The following is a description of a gene set: Human Gene Set: MANNO_MIDBRAIN_NEUROTYPES_HNBML5 from publication La Manno G, Gyllborg D, Codeluppi S, Nishimura K, Salto C, Zeisel A, Borm LE, Stott SRW, Toledo EM, Villaescusa JC, Lönnerberg P, Ryge J, Barker RA, Arenas E, Linnarsson S (PMID 27716510) Cell types are named using anatomical and functional mnemonics prefixed by 'm' or'h' to indicate mouse and human respectively: OMTN, oculomotor and trochlear nucleus; Sert, serotonergic; NbM, medial neuroblast; NbDA, neuroblast dopaminergic; DA0-2, dopaminergic neurons; RN, red nucleus; Gaba1-2, GABAergic neurons; mNbL1-2, lateral neuroblasts; NbML1-5, mediolateral neuroblasts; NProg, neuronal progenitor; Prog, progenitor medial floorplate (FPM), lateral floorplate (FPL), midline (M), basal plate (BP); Rgl1-3, radial glia-like cells; Mgl, microglia; Endo, endothelial cells; Peric, pericytes; Epend, ependymal; OPC, oligodendrocyte precursor cells. studied in species Homo sapiens, and this is the list of marker genes: PGM2L1, NPTXR, HIVEP3, SPEG, CACNA1G, FBXL12, TAL1 (NCBI Gene Id 6886), THSD7A, CHN2, FGF14, TSIX, PLEKHA6, FICD, RAB11FIP4, DPYSL3, KIF21B (NCBI Gene Id 54770), OPCML, PLPPR1, FRY, CDH13, AFF2, CELF3 (CUGBP Elav-like family member 3), STXBP1, JAKMIP2, SLC38A1, FABP3, HOOK1 (hook microtubule tethering protein 1), GPR137C, NREP, PLPP2, SCN8A, CD24, NOVA1, DACT1, DOT1L, KDM5B, SBK1, MAPRE3, CLUL1, FNDC9, NCDN (NCBI Gene Id 23154), OPN5 (NCBI Gene Id 221391), CEP126, TNFRSF6B, SCAI, ZNF793, ZNF776, MEG3, PLXNA4, ZHX1, CRACD, TMEM132B, PPP1R17, SPEF1, KLF7, PRKAR2B, USP49, GRIP1, HBB, ZNF697, TCERG1L, PTPRO, GABRB2, SSBP3, GRIA4 (NCBI Gene Id 2893), ADD2, PHACTR3, PDS5B, NXPH2, DCC, BSN, PCDH7, ARPP21, GATA3, SLC37A1, SRRM3, KALRN, ST18, DGKE, FUT9, PITPNC1, RBFOX2, ZFHX3, MTUS2, PRKCB, MAP6, UBE2QL1, ATCAY, VSTM2B, ZNF195, PAK3, GRM7, CNTNAP2, PLXNA3, FOXA2, CACNG2, SMAD9, ENO2, NRXN1, USP27X, ANKRD13B, CTSC, SOX1, PHF21B, RIMS4, TAC1, LONRF2, CORO2A, PAQR5, L1CAM, PSD2, BICD1, DOK6, SEPTIN3, SAMD11, FAM117B, BASP1, SEC31B, LMTK3, SIX3, PRKACB, PHYHIPL, MYT1, AATK, NOL4, DNER, TMEM121B, EYA1, ACVR1B, RBFOX1, LARP1B, TMEM192, SLITRK4, TSPOAP1, STRIP1, AKAP1, KIRREL3, C22orf42, DMTN, BEND4, GRIA1, CCDC112, NKAIN2 (NCBI Gene Id 154215), CMIP, ROBO2, REEP2, ATP8A1, AUTS2, SRRM4, SLC16A9, NCAN, SNAP25, LINGO1, DUSP26, NELL1, BHLHE22, NCS1, UNC13A, ENC1, TUBB3, NAV1 (neuron navigator 1), SLC12A5, TRHDE-AS1, CDH4, ZNF117, YWHAG, DUSP4, PTPRT, OSBPL6, SOX14, SULT4A1, GPR26, KSR2, POU2F1, ANKS1B, PAX5, PPFIA2, STK32B, USH2A, LMO1, TAFA2, KIF5C, KCNH8, SMPD3 (NCBI Gene Id 79756), MSANTD3-TMEFF1, CELF5, CBLN4, RCOR2, MAP3K9 (NCBI Gene Id 4293), XPR1, NOVA2, NALF1, PLXNC1, RGS7BP, RALGPS1, APBA2, MVB12B, GAD2, ABLIM3, ZNF385D, CADPS, RYR2, SIX3-AS1, ROBO1, FGF9, APLP1, PDP1, PAPPA, IRX2, ELAVL4, INSM1, CHST1, ACVR2A, TMOD2, TAOK3, SPOCK3 (SPARC (osteonectin), cwcv and kazal like domains proteoglycan 3), NBEA, SYTL2, RIMS2, PEG3, FMN2, STMN4, SYNPR, SH3BP5, CCDC85B, TAGLN3, LRRTM2, SLC8A2, RIMS1, MLLT11, MMP24, GATA3-AS1, PAPPA2, MFSD6, EPB41, PDZD7, AJAP1, HS3ST4, ONECUT1, GABRA1, CXADR, LHX5-AS1, COMTD1, TMEM169, HS6ST3, ANK3, ASXL3, HDAC1, ADGRB3, MAP1B, FSD2, MAST1, NSG2, MAP2, TRIM13, EMX2, PROX1, LHFPL4, SOX11, APC2, ESRRG, NEDD4L, SNORA12, DICER1, ZNF283, TENM1, CELSR3, APOL6, HCN3, GSE1, ASIC1, KIF21A, MACROH2A2, NRXN3, TSHZ2, TERF2IP, TENM2, OPTN, ANKRD44, DLG3, IGBP1, SEZ6L2, NSG1, HERC1, TLCD3B, NAP1L3, SCRT2, MDGA1, ATOSA, LMOD3, TRIM67, NALCN, ANKIB1, SCN3A, BCL11A, ELAVL2, TOX2, KLC1, MCF2, DCX (NCBI Gene Id 1641), TUBB2B, F11R, GNG3, SHISA2, MDGA2, KLHL14, RIPOR2, JPH4, NTNG1, ERC2, MARK1, PNOC, SRCIN1, SHANK2, MACO1, KLHL35, CLCN4, DNAJC16, RNF112, TCERG1, SCD5, MIAT, SYBU, GPR12, TMCC1, AASDHPPT, SCN3B, PIANP, FRMD5, DNAJC6, CPEB4, PLXNA2, GPM6A, EMX2OS, IRGQ, GNPTAB, CDK5R1, NFASC, ZC3H12C, PCDH11X, NRXN2, ATP1A3, ZBTB43, EFCAB7, CELF4, SYT13, PAK5, CPEB2, GPC2, KCNMA1, TRIM36 (NCBI Gene Id 55521), VSTM2A, EPHA3, NMNAT2, MYT1L, XKR6, IRF2BPL, UCP3, WNT11, RUNX1T1, NCAM1, PTPRN2, ACTL6B, TP53I11, GRIA2, CCDC85A, GAD1, STMN2, NNAT, TMEM35A, DSCAM, PNMA2, CNGB1, SHISAL1, DNM3, SLCO3A1, SCN2A, KCNC1, INA, GOLGA8B, SLITRK1, SLC32A1, CACNB3, GATA2, SV2A, GABRG2, DACT3, CPEB3, MICU3, ANK2, MUC19, LHX1, CRMP1, FTO, ZFPM2, TCAF1, ADARB2, MED12L, PLPPR2, SLC9A6, NDRG4, RPH3A, IGFBPL1, AKR1C1, RAPGEF5, ZFHX2, ELAVL3, SOX4, AMPH (NCBI Gene Id 273), ARFGEF3, PPP2R3A, PCDH9, APC, GNG2, MAP7D2, LPIN1, B3GALT2, GNAO1, SCARNA22, PBX3, ADAT2, FSCN1 (NCBI Gene Id 6624), GRIP2, VASH2, FAM81A, BZW2, ZFHX4, LRATD1, BCL11B, PTPN5, ZNF441, CASKIN1, HBA1, RAP1GAP2, KCNMB2 (potassium calcium-activated channel subfamily M regulatory beta subunit 2), CD2, LRCH2, PRSS12, TOX3, CSRNP3, NUAK1, ST8SIA3, CASZ1, RTN1, ASIC4, MAPK8, XKR4, NLN, CHGA, UBN2, MIR124-2HG, POU2F2, PDE11A, VSNL1, LINC00205, PCGF3, CNR1, KCNC2, C1orf35, TSPYL4, SERTAD4, AMER3, SAMD14, NKX2-2, AMER2